The following is a description of a gene set: studied in species Mus musculus Genes containing one or more binding sites for (Smyd2) in their promoter regions (TSS -1000,+100 bp) as identified by GTRD version 20.06 ChIP-seq harmonization. from publication Yevshin I, Sharipov R, Kolmykov S, Kondrakhin Y, Kolpakov F (PMID 30445619) Mouse Gene Set: SMYD2_TARGET_GENES, and this is the list of marker genes: Btg1b, Ccdc7b, Lamb1, Gata6os, Hcn3, Unc45b, Srrm1 (NCBI Gene Id 99965), Gata6, Shprh